The following is a description of a gene set: species: Homo sapiens Enables the transfer of oxalate from one side of a membrane to the other. Oxalate, or ethanedioic acid, occurs in many plants and is highly toxic to animals. Human Gene Set: GOMF_OXALATE_TRANSMEMBRANE_TRANSPORTER_ACTIVITY, and this is the list of marker genes: SLC26A3, SLC26A6, SLC26A8, SLC26A10P, SLC26A1, SLC26A5, SLC26A9, SLC26A2, SLC26A4, SLC26A7